The following is a description of a gene set: Activation of the mRNA upon binding of the cap-binding complex and eIFs, and subsequent binding to 43S species: Homo sapiens Human Gene Set: REACTOME_ACTIVATION_OF_THE_MRNA_UPON_BINDING_OF_THE_CAP_BINDING_COMPLEX_AND_EIFS_AND_SUBSEQUENT_BINDING_TO_43S, and this is the list of marker genes: RPS4Y1, EIF4H, EIF3F, RPS6, RPS15, RPS16, EIF2S3, EIF4A2, RPS25, RPS2, RPS24, EIF3C, RPS12, EIF3L, EIF3A, EIF4E, EIF3K, RPSA, RPS5, EIF3M, RPS23, EIF3J, RPS4Y2, RPS28, RPS27L, RPS3A, EIF4EBP1, EIF3H, RPS9 (NCBI Gene Id 6203), EIF2S2, EIF1AX, EIF3I, RPS29, RPS3, RPS27A, EIF4B, EIF4A1, EIF3B, RPS4X, EIF2S1, EIF3E, RPS27, RPS11, RPS18, RPS10, RPS8 (NCBI Gene Id 6202), EIF4G1, EIF3D, RPS26 (NCBI Gene Id 6231), RPS7, FAU, RPS17, RPS15A, EIF3G, RPS20, RPS14, RPS19, RPS13, PABPC1, RPS21